Given this list of marker genes DPH2, SHMT1, OGFOD1, ARHGEF12, KAT2A, TUBB2A, ING4, TBC1D15, CCND1, IER5, ATIC, MTHFD1, YWHAG, SFXN2, MVK, NME1, H3C1, LDB1, NTMT1, NUBP2, RAD23A, WDR4, ZKSCAN8, SIGMAR1, BIVM, MCCC2, USP20, EXD2, SEC61A1, MEN1, ACER1, SF3B5, LDAH, MRPL38, DENND6B, CREBBP, NDST1, PRPF19, NBEAL2, SLC35B2, TXN2, ADO, NELFA, TM9SF3, TICRR, FMR1, SMARCC1, NSD1, MDN1, ROR2, FADS3, OPLAH, GTF2I, FZD5, RBKS, ASCL2, PXN, GET1, SSX2IP, CENPA, DAG1, SNRPF, COMMD9, PMM1, NFKB2, MCM7, SLC6A6, OGFR, SDC1, AKT1S1, ABCB8, QTRT1, SIVA1, BCL2L1 (BCL2 like 1), PMF1, IKBKG, PLK3, HNF1B, SAPCD2, LARGE2, SEMA4D, PABPC4, TELO2, HIPK1, TRMT6, YJU2, ATF6, ABCC10, ACER2, LIG3, LFNG, TFIP11, HSPBAP1, PSRC1, ATMIN, COLGALT1, SEMA3B, RRP9, FHOD1 (NCBI Gene Id 29109), SHMT2, ZFP2, LIMS1, DOCK9, JADE1, NFIC, ARFGEF1, PSMB9, BCAS3, PKN3, POLA2, GTPBP3, AMMECR1, GEMIN5 (gem nuclear organelle associated protein 5), SGCB, NOL9, TGIF2, FEM1B, RASSF4, MAPK7, CINP, SH3D19, PPP1R15B, BDNF, NEUROG3, BCL7C, IMPACT, GORASP1, ATRIP, INTS1, IGF2, SYTL1 (synaptotagmin like 1, NCBI Gene Id 84958), ATL2, TFRC, ZFP28, CDX2, PIAS4, TP53RK, CCT4, THOP1, TMEM141, SART3, POLE (DNA polymerase epsilon, catalytic subunit), EXOSC1, NUB1, OTUB1 (NCBI Gene Id 55611), EPB41, TRIM7, TTC27, EIF2AK3, ALKBH2, NOL8, NHP2, OXR1, PIP5K1A, CARD11, MCM3, KPTN, CXXC1, CITED1, HIRA, DKC1, KNSTRN, NPTX2, PHGDH, SKIC3, ACHE, ADISSP, ACP3, MYBBP1A, SFSWAP, DHRSX (NCBI Gene Id 207063), ZBTB21, UBALD1, VPS51, TKT, NFKBIL1, TXNRD2, TXLNA, TAF7, CCSER2 (coiled-coil serine rich protein 2), UBE2K, TP53, USF1, PTPRS, VEZT, DNMBP, PRRC2C, TRAPPC6A, MED22, CORO1C (NCBI Gene Id 23603), VIPR1, METTL1, SCRN2, ABHD14A, CTDSP2, ANKRD39, RNF38, LHPP, MINDY1, MYC, SMPD4, DDX49, C18orf54, COX10, LMNB2, NDRG1, ZFP64, GAS8, VARS1, ZMYND19, YAE1, WIPI2, HOMER1, SCAMP4, EIF4G1, SOX4, MIF, FAM83G, WDR62, SRSF2 (serine and arginine rich splicing factor 2), CDC42BPA, ZNF213, DNM1L, KLF6, ATP2A3, IMPDH2, FOXM1, ERCC4, GTF3C1, WDR33, POFUT1, CFAP410, BMP7, TNFRSF12A, SLC1A3, ZBTB48, DHCR24, ZNF444, HSP90AB1, DCUN1D3, CTBS, here is a description of the gene set: from publication Sansom OJ, Meniel VS, Muncan V, Phesse TJ, Wilkins JA, Reed KR, Vass JK, Athineos D, Clevers H, Clarke AR (PMID 17377531) Human Gene Set: SANSOM_APC_MYC_TARGETS studied in species Mus musculus The APC gene encodes the adenomatous polyposis coli tumour suppressor protein, germline mutation of which characterizes familial adenomatous polyposis (FAP), an autosomal intestinal cancer syndrome. Inactivation of APC is also recognized as the key early event in the development of sporadic colorectal cancers, and its loss results in constitutive activity of the beta-catenin-Tcf4 transcription complex. The proto-oncogene c-MYC has been identified as a target of the Wnt pathway in colorectal cancer cells in vitro, in normal crypts in vivo and in intestinal epithelial cells acutely transformed on in vivo deletion of the APC gene; however, the significance of this is unclear. Therefore, to elucidate the role Myc has in the intestine after Apc loss, we have simultaneously deleted both Apc and Myc in the adult murine small intestine. Here we show that loss of Myc rescued the phenotypes of perturbed differentiation, migration, proliferation and apoptosis, which occur on deletion of Apc. Remarkably, this rescue occurred in the presence of high levels of nuclear beta-catenin. Array analysis revealed that Myc is required for the majority of Wnt target gene activation following Apc loss. These data establish Myc as the critical mediator of the early stages of neoplasia following Apc loss. Genes down-regulated after double Cre-lox knockout of both APC and MYC in small intestine.